The following is a description of a gene set: species: Mus musculus Mouse Gene Set: GOMF_SUPERCOILED_DNA_BINDING Binding to supercoiled DNA. For example, during replication and transcription, template DNA is negatively supercoiled in the receding downstream DNA and positively supercoiled in the approaching downstream DNA., and this is the list of marker genes: Top1, Rps3, Hmgb2, Hmgb1, Psip1